Given this list of marker genes Peg12, Lancl3, Mesp2, Ybx2 (Y box protein 2), Tgif2, Shisa7, Nrxn2, Fam83f, B3gnt8, Cd164l2, Hsd11b2, Ank1, Col23a1, Kl, Myo5c, Aunip, Dlgap1, Basp1, here is a description of the gene set: from publication Meissner A, Mikkelsen TS, Gu H, Wernig M, Hanna J, Sivachenko A, Zhang X, Bernstein BE, Nusbaum C, Jaffe DB, Gnirke A, Jaenisch R, Lander ES (PMID 18600261) Genes with high-CpG-density promoters (HCP) bearing histone H3 dimethylation mark (H3K4me2) in brain. DNA methylation is essential for normal development and has been implicated in many pathologies including cancer. Our knowledge about the genome-wide distribution of DNA methylation, how it changes during cellular differentiation and how it relates to histone methylation and other chromatin modifications in mammals remains limited. Here we report the generation and analysis of genome-scale DNA methylation profiles at nucleotide resolution in mammalian cells. Using high-throughput reduced representation bisulphite sequencing and single-molecule-based sequencing, we generated DNA methylation maps covering most CpG islands, and a representative sampling of conserved non-coding elements, transposons and other genomic features, for mouse embryonic stem cells, embryonic-stem-cell-derived and primary neural cells, and eight other primary tissues. Several key findings emerge from the data. First, DNA methylation patterns are better correlated with histone methylation patterns than with the underlying genome sequence context. Second, methylation of CpGs are dynamic epigenetic marks that undergo extensive changes during cellular differentiation, particularly in regulatory regions outside of core promoters. Third, analysis of embryonic-stem-cell-derived and primary cells reveals that 'weak' CpG islands associated with a specific set of developmentally regulated genes undergo aberrant hypermethylation during extended proliferation in vitro, in a pattern reminiscent of that reported in some primary tumours. More generally, the results establish reduced representation bisulphite sequencing as a powerful technology for epigenetic profiling of cell populations relevant to developmental biology, cancer and regenerative medicine. species: Mus musculus Mouse Gene Set: MEISSNER_BRAIN_HCP_WITH_H3K4ME2